The following is a description of a gene set: Reactome Pathway: Ubiquitin-Mediated Degradation of Phosphorylated Cdc25A part of: p53-Independent G1/S DNA Damage Checkpoint studied in species Mus musculus This event has been computationally inferred from an event that has been demonstrated in another species.<p>The inference is based on the homology mapping from PANTHER. Briefly, reactions for which all involved PhysicalEntities (in input, output and catalyst) have a mapped orthologue/paralogue (for complexes at least 75% of components must have a mapping) are inferred to the other species. electronically inferred by orthology from the curated human pathway, and this is the list of marker genes: Psma2, Csnk1a1, Psmc3, Mapk11, Ubb, Psmc5, Psmd6, Chek2, Psmd7, Psmc2, Psma6, Nek11, Psma1, Psmc1, Psmd1, Psma5, Psmd13, Psmb6, Psmc6, Psmb5, Psmb4, Mapk14 (mitogen-activated protein kinase 14), Psmc4, Csnk1e, Psma7, Psmb7, Psma4, Rps27a, Psma3 (NCBI Gene Id 19167), Cul1, Psmd12